Given this list of marker genes ADD1, ERMAP, EPB41, ACTB, ADD2, TPM3, ADD3, EPB42, ANK1, SPTB, SLC4A1, SPTA1, TMOD1, DMTN, here is a description of the gene set: Major erythrocyte membrane genes. Erythrocyte membrane protein genes serve as excellent models of complex gene locus structure and function, but their study has been complicated by both their large size and their complexity. To begin to understand the intricate interplay of transcription, dynamic chromatin architecture, transcription factor binding, and genomic organization in regulation of erythrocyte membrane protein genes, we performed chromatin immunoprecipitation (ChIP) coupled with microarray analysis and ChIP coupled with massively parallel DNA sequencing in both erythroid and nonerythroid cells. Unexpectedly, most regions of GATA-1 and NF-E2 binding were remote from gene promoters and transcriptional start sites, located primarily in introns. Cooccupancy with FOG-1, SCL, and MTA-2 was found at all regions of GATA-1 binding, with cooccupancy of SCL and MTA-2 also found at regions of NF-E2 binding. Cooccupancy of GATA-1 and NF-E2 was found frequently. A common signature of histone H3 trimethylation at lysine 4, GATA-1, NF-E2, FOG-1, SCL, and MTA-2 binding and consensus GATA-1-E-box binding motifs located 34 to 90 bp away from NF-E2 binding motifs was found frequently in erythroid cell-expressed genes. These results provide insights into our understanding of membrane protein gene regulation in erythropoiesis and the regulation of complex genetic loci in erythroid and nonerythroid cells and identify numerous candidate regions for mutations associated with membrane-linked hemolytic anemia. Human Gene Set: STEINER_ERYTHROCYTE_MEMBRANE_GENES from publication Steiner LA, Maksimova Y, Schulz V, Wong C, Raha D, Mahajan MC, Weissman SM, Gallagher PG (PMID 19687298) studied in species Homo sapiens